The following is a description of a gene set: studied in species Mus musculus Any process that increases the activity of a ryanodine-sensitive calcium-release channel. The ryanodine-sensitive calcium-release channel catalyzes the transmembrane transfer of a calcium ion by a channel that opens when a ryanodine class ligand has been bound by the channel complex or one of its constituent parts. Mouse Gene Set: GOBP_POSITIVE_REGULATION_OF_RYANODINE_SENSITIVE_CALCIUM_RELEASE_CHANNEL_ACTIVITY, and this is the list of marker genes: Calm3, Calm2, Gstm7, Calm1, Jph2, Gsto1